The following is a description of a gene set: Mouse Gene Set: GOBP_VENTRICULAR_SYSTEM_DEVELOPMENT species: Mus musculus The process whose specific outcome is the progression of the brain ventricular system over time, from its formation to the mature structure. The brain ventricular system consists of four communicating cavities within the brain that are continuous with the central canal of the spinal cord. These cavities include two lateral ventricles, the third ventricle and the fourth ventricle. Cerebrospinal fluid fills the ventricles and is produced by the choroid plexus., and this is the list of marker genes: Slc7a11, Aqp1, Dbi, Sema6d, Tsku, Wdr89, Mboat7, Rpgrip1l, Mecp2, Coro1c, Ccdc134, Ulk4, Rapgef2, Nfix, Ak8, Hydin, Uchl5, Bbs1 (Bardet-Biedl syndrome 1), Kif27, Mnat1, Anp32b, Myh10, Numb, Ttn, Nme5, Atp1b2, Celsr2, Spag6l, Kdm2b, Ttc21b, Dpcd, Dnah5 (NCBI Gene Id 170953), Odad2, Pax5, Numbl, Bbs4, Grcc10